Given this list of marker genes HAS3, HAS1, IL1B, AP2A1, SMPD3, CLTC, PDGFB, ABCC5, CEMIP, HAS2, EGF, TGFB1, NFKB1, here is a description of the gene set: species: Homo sapiens Human Gene Set: GOBP_HYALURONAN_BIOSYNTHETIC_PROCESS The chemical reactions and pathways resulting in the formation of hyaluronan, the naturally occurring anionic form of hyaluronic acid. Hyaluronan is a type of non-sulfated glycosaminoglycan composed of the repeating disaccharide unit beta(1,4)-D-glucuronic acid-beta(1,3)-N-acetyl-D-glucosamine.